The following is a description of a gene set: Human Gene Set: GOBP_POSITIVE_REGULATION_OF_SMOOTH_MUSCLE_CELL_DIFFERENTIATION species: Homo sapiens Any process that activates or increases the frequency, rate or extent of smooth muscle cell differentiation., and this is the list of marker genes: PIAS1, TGFB1, OLFM2, SMARCD3, MIR140, CTH, NOTCH4 (notch receptor 4), KIT, MIR18A, SOD2, MIR34A, MIR125B1 (microRNA 125b-1), GPER1, NOTCH2, MIR424 (microRNA 424), EFEMP2, SHH, MIR145, SIRT1, ENG, NOTCH1 (notch receptor 1), MIR21, MIR1-1, MIR22, MYOCD